Given this list of marker genes RB1, CASP9, PRKCH, PRKCA, TNFRSF21, CASP3, CCL2, TRAF2, TREM2, CERS6, TP53, GAS6, PRKCD, PRKCI, RAD21, DLL1 (NCBI Gene Id 28514), AKAP12, here is a description of the gene set: species: Homo sapiens Human Gene Set: GOBP_GLIAL_CELL_APOPTOTIC_PROCESS Any apoptotic process in a glial cell, a non-neuronal cell of the nervous system.